Given this list of marker genes IQGAP2, CLEC4C, HEXIM1, MARCHF8, YWHAB, JAK2, CCPG1, CARD6, STK17B, GTF2H2, TMEM43, NDC80, DUSP1, METTL4, TTLL12, NOTCH2 (notch receptor 2, NCBI Gene Id 55574), CNTNAP3B, TBCB, SELP, HAUS4, LPCAT3, MIIP, CAMP, HMOX2, DSC2, ATM, YWHAH, RRP12, ARB2A, ACOX1, ZBTB34, CAMK1D, CLC, PGLS, APAF1, MYO5A, SYNE2, TUBA1C (NCBI Gene Id 84790), ABHD3, RAB5IF (RAB5 interacting factor), XRN2, TST, WLS, HSPA8, CDS2, UBR3, RFLNB, ZYG11B, USP6, MGRN1, REX1BD, MIR21, RNF135, H3C1, KIAA0319L, CD33, TBC1D14, RALGAPA2, MTARC1, LAMTOR4, LILRA2, IQGAP1, INTS3, GCNA, FLOT2, CASP8, ROPN1L, SELPLG, TLR1, PTTG2, RAB18, SLC8B1, CAPN1, DCBLD1, FAM117B, LRP10, KIT, TOPORS, MTM1, DENND10, UBE2E3, NUCB1, KCTD21, PADI4, USP32, HK3, MEGF6, PRRG4, KIF21B, NUDT16, GEMIN7, BICD2, SMAP2, GAA, REEP5, ARHGAP26, MSRB2, ZFP36, ADD3, MAPK1, MFSD14B, VPS4B, JUNB, EPB41, PTPN18, THOC5, WDFY4, CAB39, PBXIP1, MPZL1, IKBIP, CYP4F3, MARCHF7, ATP7B, AGO4, STXBP5, FKBP9, FCGR3B, ZMPSTE24, SMPD3, CERS2, IPCEF1, VCL, GLUD1, HHEX, NRBF2, FBXL5, RAB3D, TMT1A, LPCAT2, CD46, ARHGAP1, RAB11FIP1, DEF8, MVP, TOB1, MMGT1, MPRIP, NDUFB3, SLC25A44, APBB1IP, ATP5F1E, PHKA2, DUSP6, FAM117A, PPP1R12A, DPY19L3, ICAM3, ATF6, MNDA, DENND1A, NUDT5, IRF2BPL (interferon regulatory factor 2 binding protein like), ZNF467, SULT1B1, ADAM19 (ADAM metallopeptidase domain 19), YIPF1, NHS, TSPO, MANSC1, LY75, SLC8A1, TBL1X, HSDL2, RBM14, TMEM219, CSAD, S100A6, JPT1, RMI1, NLRP12, CPNE2, PRDX3, CX3CR1, HENMT1, DYSF, RPGRIP1, ANKRD50, H2BC4 (H2B clustered histone 4), LSM2, SPINT1, VPS37B, ARHGAP19, ADD1, RPGR, CREB5, MIR646HG, ACTN4, PPP1CA, RELL1 (NCBI Gene Id 768211), TREML2 (NCBI Gene Id 79865), NUP214, UBE2D1, ZBTB44, TLE4, DPYD (NCBI Gene Id 1806), SLC12A9, here is a description of the gene set: species: Homo sapiens Human Gene Set: GSE37416_0H_VS_12H_F_TULARENSIS_LVS_NEUTROPHIL_UP from publication Schwartz JT, Bandyopadhyay S, Kobayashi SD, McCracken J, Whitney AR, Deleo FR, Allen LA (PMID 22986450) Genes up-regulated in comparison of control polymorphonuclear leukocytes (PMN) at 0 h versus PMN treated with F. tularensis vaccine at 12 h. We demonstrated recently that both constitutive and FAS-triggered apoptosis of human neutrophils are profoundly impaired by Francisella tularensis, but how this is achieved is largely unknown. To test the hypothesis that changes in neutrophil gene expression contribute to this phenotype, we used human oligonucleotide microarrays to identify differentially regulated genes in cells infected with F. tularensis strain LVS compared with uninfected controls. In order to examine the effect of F. tularensis on the neutrophil transcriptome, we performed microarray expression analysis on human neutrophils treated with F. tularensis subsp. holarctica live vaccine strain (LVS).